Given this list of marker genes RMI1, SLC6A5, HDAC9, ATP6V0A1, HOXA4, UNC45A, DLC1, TBX6, IL19, CITED2, PRDM1, MPPED2 (NCBI Gene Id 744), MEF2C, NR4A3 (nuclear receptor subfamily 4 group A member 3), PDGFRA, TENM3-AS1 (NCBI Gene Id 90768), FRMPD1, RCAN1, CNTLN, PPP2R2B, FGF19, BUB3, MIR17HG, SETD2, MEIS2, BARHL2, PLPP1, PHF12, GPR21, HNF1A, IL21, CASZ1, KRT32 (keratin 32), HOXB5 (NCBI Gene Id 3215), EN1, SRSF6, SELENON, GDAP1L1, EVA1A, RIMS2, ACP6, LINC00052, IGFL3, CDKN2C, GRWD1, COL4A5, RNF148, MYLK, COL8A1 (collagen type VIII alpha 1 chain), OTX2, TOGARAM1, FEZF2, PTCHD4, PLXNA2, ZNF385B, MED24, SOX5 (NCBI Gene Id 6660), KLF12, JPH1, TP53BP1, AP1G1, WNT8B, JAG1, DLGAP4, TMEM178A, BAMBI, GRAMD1C, WDPCP, FOXN3, HOXD4, LMO4, RPLP0, NR1D1, MTMR11, FGD4, DLX2, CHCHD7, AMD1, RIT1, RBFOX1, PLEC, ARSB, KMT5C, TMOD3, TFIP11 (tuftelin interacting protein 11), SALL1, LTBP2, DAB1, NEK7, CACNG2, EMX2, MS4A7, DYRK1A, VPS45, CDH22, STAG2, KIF2B, SLC6A11, CX3CR1, TMTC2, DMD, TP53I11, AAK1, ENSG00000291228, DCN, SLF2, DNAJB8, DMC1, HOXC4, JPH3, POLDIP3, ZNF423, MLIP, FBXO11, GSX1, HOXA3, FOXO3, MITF, NRP2, FGF13, BMP4, PPP2CA, BEND4, DLX1, LIFR, CACNA2D3, MBNL1, ELK3, PIPOX, MOAP1 (modulator of apoptosis 1), SLC7A11, ASB18, UBE2K, RPS6KB1, SOX14, LMO3, MCTP1, GFI1B, DDX17, SKIL, PLAG1, MID1, LINC01597, PAIP2, KCNQ4, NPTX2 (NCBI Gene Id 95714, neuronal pentraxin 2), ANKS1B, CLVS1 (clavesin 1), NAP1L2, SMPX, ISL1, HTN1, PLPP7, RNF11, FAM53B, SNX12 (NCBI Gene Id 29934), GPR119, PTPRG, FAM53C, CTNND2, TNMD, AP5M1, ARHGEF7, FNBP4, TMPRSS3, TMEM132E-DT, CREB5, PIAS1, NRP1, RCOR2, TGM4, PRKG1, BDNF, RCAN2, LMO1, TAC3, RPA3, NPVF, ERRFI1, GPC3, EYA1, TCF4, OTUD7B, BACH2, ANAPC15, ZNF654, PLEKHH3, GLDN, ARL1, JUP, NEO1, IL1RAPL1, DPY30, HOXB4, FLRT1, KLHL28, NDST1, AP1S2, NOL4, AJUBA, FRA10AC1, TEX264, DRD3, SEMA3A, HNRNPK, NFKBIA, PABIR2, DPH5, WDR47, UBE2D3, NFIX, RUNX1T1, FAP, CHD2, TBL1X, TENT4B, FOXP2, RFT1, FBXW7, TFAP2D, MPP4, ATOH7, CIMIP6, DCTN3, FAM89A, EXOC5, PALS1, TLK1, TCEAL7, KDM4A, CDH6, ZFP36L1, BCL2L2, PPARG, MIR9-1HG, ATL3, PHOX2B, here is a description of the gene set: species: Homo sapiens Genes having at least one occurrence of the motif NNNRTAATNANNN in the regions spanning 4 kb centered on their transcription starting sites. This matches the POU2F1 transcription factor binding site V$OCT1_03 (v7.4 TRANSFAC). Human Gene Set: OCT1_03